Given this list of marker genes LRRC14, DUSP7, UBC, RELA (RELA proto-oncogene, NF-kB subunit), TLR6, MAPK10, MAPK7, PPP2CB, ALPK1, TIRAP, IRAK3, SOCS1, CHUK, UBA52, NLRX1, SAA1, FGG, LY96, MAPK3, BTRC, NFKBIA, S100B, TAB2, S100A12, FOS, USP14, MAPK8, FGB, RPS6KA5, TLR4, TLR2, DUSP6, MAPK1, NFKB2, RPS6KA3, APP, CD36, IKBIP, MAPKAPK3, FBXW11, MAPK14, S100A9, RPS6KA1, S100A8, TAB3, MAP2K7, RIPK2, DUSP4, IKBKB, HMGB1, UBB, NKIRAS2, PELI2, IKBKG, S100A1, TIFA (TRAF interacting protein with forkhead associated domain), MAP2K1, MAP3K1, DUSP3, CD14, CUL1, NLRC5, SKP1, TAB1, MAPK11, MAP2K3, MYD88, TRAF6, UBE2N, VRK3, PELI1, USP18 (NCBI Gene Id 11274), ATF1, NFKB1, PPP2R1B, ELK1, BTK, NOD1, MEF2A, NOD2, MAP3K7 (mitogen-activated protein kinase kinase kinase 7), mip, ECSIT, RPS6KA2, TP53, IRAK4, SIGIRR, NKIRAS1, CREB1, PELI3, ATF2, TLR1, MAP2K4, PPP2R1A, N, porB, RPS27A, PPP2CA, N4BP1 (NEDD4 binding protein 1), CASP8 (NCBI Gene Id 841), MAP2K6, NFKBIB, PPP2R5D, JUN, UBE2V1, MAP3K8, MAPKAPK2, IRAK1, AGER, IRAK2, TNIP2, TRAF2, MEF2C, MAPK9, FGA, here is a description of the gene set: part of: Toll Like Receptor 4 (TLR4) Cascade; Toll Like Receptor TLR1:TLR2 Cascade; Toll Like Receptor TLR6:TLR2 Cascade Reactome Pathway: MyD88:MAL(TIRAP) cascade initiated on plasma membrane species: Homo sapiens The first known downstream component of TLR4 and TLR2 signaling is the adaptor MyD88. Another adapter MyD88-adaptor-like (Mal; also known as TIR-domain-containing adaptor protein or TIRAP) has also been described for TLR4 and TLR2 signaling. MyD88 comprises an N-terminal Death Domain (DD) and a C-terminal TIR, whereas Mal lacks the DD. The TIR homotypic interactions bring adapters into contact with the activated TLRs, whereas the DD modules recruit serine/threonine kinases such as interleukin-1-receptor-associated kinase (IRAK). Recruitment of these protein kinases is accompanied by phosphorylation, which in turn results in the interaction of IRAKs with TNF-receptor-associated factor 6 (TRAF6). The oligomerization of TRAF6 activates TAK1, a member of the MAP3-kinase family, and this leads to the activation of the IkB kinases. These kinases, in turn, phosphorylate IkB, leading to its proteolytic degradation and the translocation of NF-kB to the nucleus. Concomitantly, members of the activator protein-1 (AP-1) transcription factor family, Jun and Fos, are activated, and both AP-1 transcription factors and NF-kB are required for cytokine production, which in turn produces downstream inflammatory effects.